Given this list of marker genes HMGB1, CD74, TNF, POSTN, MIF, TGFB1, TLR4, DEFB124, LPL (NCBI Gene Id 4023), TIRAP, MBP, MCOLN2, here is a description of the gene set: Any process that activates or increases the frequency, rate or extent of chemokine (C-X-C motif) ligand 2 production. studied in species Homo sapiens Human Gene Set: GOBP_POSITIVE_REGULATION_OF_CHEMOKINE_C_X_C_MOTIF_LIGAND_2_PRODUCTION